The following is a description of a gene set: The process in which a phosphate is transported across a membrane. Human Gene Set: GOBP_PHOSPHATE_ION_TRANSMEMBRANE_TRANSPORT species: Homo sapiens, and this is the list of marker genes: SLC37A3, SLC17A7, SLC25A10, CLDN3, XPR1 (xenotropic and polytropic retrovirus receptor 1), SLC17A1, SLC37A2, VDR, SLC37A4, SLC20A2, ANKH, SLC37A1, SLC20A1, SLC34A1, SLC25A3